The following is a description of a gene set: studied in species Homo sapiens Stromal stem cells proliferate in vitro and may be differentiated along several lineages. Freshly isolated, these cells have been too few or insufficiently pure to be thoroughly characterized. Here, we have isolated two populations of CD45-CD34+CD105+ cells from human adipose tissue which could be separated based on expression of CD31. Compared with CD31+ cells, CD31- cells overexpressed transcripts associated with cell cycle quiescence and stemness, and transcripts involved in the biology of cartilage, bone, fat, muscle, and neural tissues. In contrast, CD31+ cells overexpressed transcripts associated with endothelium and the major histocompatibility complex class II complex. Clones of CD31- cells could be expanded in vitro and differentiated into cells with characteristics of bone, fat, and neural-like tissue. On culture, transcripts associated with cell cycle quiescence, stemness, certain cytokines and organ specific genes were down-regulated, whereas transcripts associated with signal transduction, cell adhesion, and cytoskeletal +CD105+CD31- cells from human adipose tissue have stromal stem cell properties which may make them useful for tissue engineering. from publication Boquest AC, Shahdadfar A, Frønsdal K, Sigurjonsson O, Tunheim SH, Collas P, Brinchmann JE (PMID 15635089) Human Gene Set: BOQUEST_STEM_CELL_UP Genes up-regulated in freshly isolated CD31- (stromal stem cells from adipose tissue) versus the CD31+ (non-stem) counterparts., and this is the list of marker genes: MAN1C1, SRPX, WNT5A, FMO1, CRYAB, SPOCK1, PID1, CEBPB, HAS1, UGDH, GDF10, IGFBP6, DCN, PDGFRA, SERPINA5, SVEP1 (NCBI Gene Id 89871), FGF7, ITGA8, MXRA8, HSPB8, NOVA1, ROBO1, MXRA5, MAFB, FLRT2, COL14A1, PLN, OLFML2B, FMOD, ALDH1A1, KCND2, PHLDA2 (NCBI Gene Id 7262), DSE, F3, DDR2, INHBA, S100A4, NOTCH2, CHRDL1, AGL, TMED3, MSC, C6, PCDH9, COL6A1, PLTP, PTGIS, ADCY7, PTGDS, TRO, MEG3, OLFML3, APOE (NCBI Gene Id 99), MEIS1, COL5A2, NT5E, CDO1, SERPINE2, STEAP1, OLFML1, SCRN1, CFD, PLBD1, CXCL12, CHL1, FAT1, NOTCH2NLA, MFAP5, LUM, GFPT2, BICC1, CAPN6, COL16A1, BHLHE41, PTPN13, RCN3, PTGFR, DCX, SFRP4, VCAN, LPAR1, BMPR1A, ANK2, PLP1, HNMT, CDKN2C, PTX3, APOD, BASP1, NPY1R, MFAP2, KCNK1, COL1A1, FBLN1, SEMA3C, NTRK2, DKK2, CD44, ACOX2, MGP, COL6A3, LOX, SUSD5, IRS1, DCLK1, MEIS2, OGN, FZD7, ITGBL1, FXYD1, EGFR, PPL, GSN, CYBRD1, LINC01140, SYNE3, GAS1, GSTM5, F10, CDH11, THBS2, TIMP1, EMP3, HOXC6, FBLN5, CFB, LSP1P5, PRRX1, SLC22A3, KIAA0930, MYOC, PRR16, COL3A1, SHOX2, LRRC17, RECK, ISLR, TNC, NIBAN1, VEGFD, AXL, GPNMB, RHOBTB3, PCOLCE2, MFAP4, OSR2, GSTM3, IRS2, MBP, TWIST1, BHMT2, C1S, CXCL14, BBS9, PRELP (proline and arginine rich end leucine rich repeat protein), FEZ1, SLIT2, PDGFD, PTPRD, C7, PAMR1, COLEC12, HTRA1, TMEM176B, COL1A2, SGCE, OGT, GPC3, SCARA3, COL5A1, LTBP2, PDGFRL, MEST, ADH1B, ROR1, ABI3BP, TMEM45A (transmembrane protein 45A), TNXA, LIF, C3, SERPINA3, MRC2, ELOVL2, ANPEP (NCBI Gene Id 290), PDE4DIP, CTSK, GALNT12, TSPAN8, ASPA, GLT8D2, IGF1, IGFBP3, AKR1C1, MITF, MYH11, RNASE4, ABCA8, LRP1, SOX9, GPC4, PTPRG, MME, DZIP1, C5orf15 (chromosome 5 open reading frame 15), SGCD, COL6A2, SLC39A14, AOX1, RERGL, CRABP2, CILP, SLIT3, ANGPT1, ABCA6, ECM2, CRIP1, SDC2, AEBP1, MMP2, WDR41, CD302, PDLIM3, FST, EFEMP1, SPON2, TGFB2, TENM1, PLA2G2A, LAMA2, C1R, PEG10, FAP, UST, FBN1, TNFAIP6, EFS, CELF2, DIPK1A (NCBI Gene Id 388650), SLC5A3, ADH1C, CRISPLD2, PLAGL1, SETBP1, ATP1A2, SLC2A10, GRIA3, LRP1B, CFH, NET1, ACKR4, ANG, HDAC4, CCN5, SSPN, DPT, OMD, PLA2G4A, SERPINF1, PCOLCE, ATP8B4, CES1, GAS7